Given this list of marker genes Bbs2, Gucy1a1, Irag1, Casr, Klf2, Plekha7, Bloc1s6, Adra2a, Adora2b, Nos1, Kcnmb1, Ins1, Kdr, Adrb2, Kcnj8, Gper1, Ptprm, Adrb3, Ednrb, Gch1, Mkks (NCBI Gene Id 99133), Agtr2, Kat2b (NCBI Gene Id 320956), Gja1, Grk2, Ext1, P2rx4, Sod2, Klk1b1, Bdkrb2, Sirt1, Esr2 (NCBI Gene Id 13983), Ptk2, Drd1, Plod3, Ext2, Gja5, Sod1, Adora2a, Rgs2, Gpx1, Npr3, Calca, Ins2, Kcnma1, Prkg1, Itga1 (NCBI Gene Id 320601), Vstm4, Cps1, Abcc9, Tnf, Nppa, Kng2, Vegfa, Kng1, Adora1, Ppard, Mas1, Cftr, Egfr, F2rl1, Atg5, Agt, G6pdx (NCBI Gene Id 14381), Adcyap1, Apoe, Adrb1, Pla2g6, Ucn, Mrgprd, here is a description of the gene set: studied in species Mus musculus Mouse Gene Set: GOBP_VASODILATION An increase in the internal diameter of blood vessels, especially arterioles or capillaries, due to relaxation of smooth muscle cells that line the vessels, and usually resulting in a decrease in blood pressure.